The following is a description of a gene set: species: Mus musculus The small subunit of a ribosome located in the cytosol. Mouse Gene Set: GOCC_CYTOSOLIC_SMALL_RIBOSOMAL_SUBUNIT, and this is the list of marker genes: Rps12, Rps27l, Rps2, Rps27rt, Larp4, Rps27, Rps17, Rps20, Dhx29, Eif2d, Rps25, Rps9, Rps21, Rps14, Rps4x, Rps11, Mcts1, Rps16, Fau, Eif2a, Rps19, Rps26, Rps6 (ribosomal protein S6), Rps15, Rps10, Rps6-ps4, Rps3, D1Pas1, Ddx3x, Rpsa, Rps7, Rps23, Rps29, Rps4l, Rps27a, Rps18, Rps24 (NCBI Gene Id 20088), Rps15a, Rps5, Rps3a1, Rps28, Rps8, Rps13